Given this list of marker genes Ccdc38, Ptprcap, Tcp1, Trmt1, Map6, Pdcd5, Tgfa (transforming growth factor alpha), Gpr15lg, Cd248, Ncl, Cct4, Prg3, Chi3l1, Klk9, Srsf1, Mcam, S100a9, Smu1, Tmem248, Qdpr, Polr1has, Snhg9, Cmpk2, Or8b12i, Plac8, 4930547E14Rik, Rab5if, Id1, Sprr2f, Lif, Eml4, Lrif1, Hbs1l, Ywhab, Smkr-ps, Plekha4, Gsk3b, Spns3, Ovol2, Lhx3, Ssu72, Eng, Map1lc3a, Ube2c, Dynll1 (NCBI Gene Id 56455), Ryr1, Nptxr, Ext2, Eef1b2, Cx3cl1, Rhoh, 1110038B12Rik, Rps3a1, Atp6v0d1, 2610042L04Rik, Pfkl, Traf2, Slpi, Pgam1, Wfdc2 (NCBI Gene Id 67701), Clvs1 (NCBI Gene Id 93777), Cpa5, H2az1, 1700105P06Rik, Homer3, Enah, Tmem65, Ifitm3, Rubcn, Sprr2b, Rbm12, Man2a2, Sun1, Lce3b, Chpt1, Ide, Foxl2, Rnf181, Arap1, Gba1, Nuf2, Dnajc1 (NCBI Gene Id 98831), Ppic, Sod1, Ftl1, Elavl1, Bbln, Mrps18a, Gnao1, Gkn3 (NCBI Gene Id 68888), Stx16, S100a8, Actg2, Cacna1e, Nrsn1, Art5, Acan, Lypd2, Sod3, Vps37a, Rab2b, Chp1, Cited2, Spic, Capn2, Irak1, Ncan (neurocan), 4921517D16Rik, Ttll11, Paqr7, Ftl2-ps, Rps6ka4, Hbb-y, Klf13, Sprr2i, Acot10, Lyz2, Nhp2, Eno1, Cxcl16, Psg28, Arhgap4, Drd5, Ctsl, Arl2, Sdr9c7, 2900064F13Rik, Ly6e, Ltbp4, Patj, Dynlt2b, Ugt2b37, Srm, Icam1, Hamp, Snhg3, Gabarapl2, Baiap2, Fabp4, Tnp2, Cox5b, Esd, Spp1, Map2k5, Apod, Pgk1, Ldha, Trp73, Axl, Car3, Batf3, Bzw1, Ltb4r1, Acta2, Plet1, Creld1, Chka, here is a description of the gene set: Mouse Gene Set: DARWICHE_SKIN_TUMOR_PROMOTER_UP Chemical induction of squamous tumors in the mouse skin induces multiple benign papillomas: high-frequency terminally benign low-risk papillomas and low-frequency high-risk papillomas, the putative precursor lesions to squamous cell carcinoma (SCC). We have compared the gene expression profile of twenty different early low- and high-risk papillomas with normal skin and SCC. Unsupervised clustering of 514 differentially expressed genes (P<0.001) showed that 9/10 high-risk papillomas clustered with SCC, while 1/10 clustered with low-risk papillomas, and this correlated with keratin markers of tumor progression. Prediction analysis for microarrays (PAM) identified genes that distinguished the two papilloma classes, and a majority of these had a similar expression pattern in both high-risk papillomas and SCC. Additional classifier algorithms generated a gene list that correctly classified unknown benign tumors as low- or high-risk concordant with promotion protocol and keratin profiling. Reduced expression of immune function genes characterized the high-risk papillomas and SCC. Immunohistochemistry confirmed reduced T-cell number in high-risk papillomas, suggesting that reduced adaptive immunity defines papillomas that progress to SCC. These results demonstrate that murine premalignant lesions can be segregated into subgroups by gene expression patterns that correlate with risk for malignant conversion, and suggest a paradigm for generating diagnostic biomarkers for human premalignant lesions with unknown individual risk for malignant conversion. Genes up-regulated during skin tumor progression: epidermis treated with the carcinogen DMBA followed by 20 weekly applications of the tumor promoter TPA, compared to the untreated skin. studied in species Mus musculus from publication Darwiche N, Ryscavage A, Perez-Lorenzo R, Wright L, Bae DS, Hennings H, Yuspa SH, Glick AB (PMID 17525749)